The following is a description of a gene set: species: Homo sapiens A delay in the acquisition of the ability to understand the speech of others. Receptive language delay Human Gene Set: HP_RECEPTIVE_LANGUAGE_DELAY, and this is the list of marker genes: FOXP2, KMT2C, GRHL3, GNB1, AGO2, RAP1GDS1, CNTNAP2, EHMT1, PAK1, AFG2A, SH2B1, ALMS1, ATP9A, UBB, FLCN